The following is a description of a gene set: The chemical reactions and pathways resulting in the breakdown of any amino acid that requires pyruvate for its synthesis, e.g. alanine. Mouse Gene Set: GOBP_PYRUVATE_FAMILY_AMINO_ACID_CATABOLIC_PROCESS studied in species Mus musculus, and this is the list of marker genes: Ivd, Mccc2, Bckdk, Auh, Mccc1, Agxt, Gpt2, Agxt2, Gpt, Hmgcll1, Hmgcl